Given this list of marker genes Nr4a1, Slc8b1, Fpr2, Pdgfd, Ednrb, Slamf9, Gpr18, Ccl8 (NCBI Gene Id 80561), Dpp4, Itgb2, Ninj1, Akirin1, Cxcl3, Vegfb, Defb6, Cxcr3, Plekhg5, Itgb2l, Mapk1, Epha2, Ccl19-ps6, Kdr, Retnlg, Ccl21e, S100a9, Nrp1, Il17rc, Hbegf, Pdgfra (platelet derived growth factor receptor, alpha polypeptide), C3ar1, Gstp1, Defb3, Bcar1, Gpr183, Trem1, Enpp2, Ccl19-ps5, Spp1, Slc12a2, Csf1r, Prkd1, Kit, Pla2g7, Rab13, Mmp28, Tnfaip6, Lbp, Defb8, Ccl21d, Mtus1, Rac3, Ephb1, Ackr2, Calr, Ccr4, Cxcr4, Msmp, Rac1, Cxcr6, Ccl21f, Cxcl14, Itga9, Sell, Tiam1, Plxnb3, C5ar1, Ccn3, Il12a, Fcgr3, Ccl3, Klrk1 (killer cell lectin-like receptor subfamily K, member 1), Hoxb9, S100a14, Csf1, Fgf1, Dusp1, Cxcr2, Arhgef16, Aif1, Vav1, Nod2, Slit2, Gpr35, Trpm2, Prkcq, Met, Hc, Cxcl16, Tmsb4x, Ccl20, Tnfsf18, Fpr-rs3, Crkl (v-crk avian sarcoma virus CT10 oncogene homolog-like), Ccl21b, Flt1, Mpp1, Hgf, Ccl19-ps4, Plec, Cxcl13, Cklf, Pf4, Ctsg, Swap70, Ptn, Ccl9, Ccl7, Tgfb2, Hmgb1, C5ar2, Srp54a, Rps19, Nup85, Cxcl15, Ripor2, Adam17, Edn3, Scg2, Fgfr1, Ifng, Cxcl12, Prkd2 (protein kinase D2), Shh, Gpsm3, Dapk2, Cxcr1, Grem1, Defb4, Gstp2, Adam10, C1qbp, Il34, Clxn (NCBI Gene Id 74659), Mif, Ccr9, Dnm1l, Mstn, Cmklr1, Rarres2 (NCBI Gene Id 71660), Sbds, Pip5k1a, Coro1b, Ccl17, Bin2, Tnfsf14, Prkca, Rpl13a, Camk1d, Ccr2, Syk, App, Ccl26, Dpep1, Ccl25, Tmem102, Ccl19-ps3, Thbs4, Prex1, Jaml, Cxadr, Itgam, Ppia (NCBI Gene Id 268373), Defb47, Gpr15lg, Defb25, Fpr-rs4, Hsd3b7, Il23a, Edn2, Egr3, Ptprj, Rhog, Agtr1a, Lef1, Cyp7b1, Cnr2, Il17ra, Il17b, Il1b, Mst1, Zfp580, Fgf16, Defb5, Fgf4, Pikfyve, Lpar1, Rac2, Ptk2b, Hspb1, Cxcl2, Defb33, Xcr1, Cx3cr1, Ccr5, Lgals3, Pde4d, Ccr3, Defb7, Mmp9, Ccl4, Abcc1, Nckap1l, Parva, Ccl19, Tirap, Mospd2, Mdk, Trem3, Ccl2, Gab1 (growth factor receptor bound protein 2-associated protein 1), Nbl1, Dock4, Csf3r, Edn1, Coro1a, Ccl12, Wnk1, Serpine1 (serine (or cysteine) peptidase inhibitor, clade E, member 1), Pde4b, Slamf8, Vcam1, Crk, Cxcl10, Spi1, S100a8, Ccl21a (C-C motif chemokine ligand 21 (serine)), Gas6, Ccl6, Ptk2, Defb46, Ccr1l1, Fgf2, Cxcl5, Il4, Ccl27a, Xcl1, Fpr-rs6, Ptpro, S1pr1, Pgf, Bst1, Vegfc, Perp, Tafa4, Vegfd, Lyst, Padi2, Tnfsf11, Cx3cl1, Hrg, Myo9b (NCBI Gene Id 17925), F2rl1, Bsg, Fcer1g, Ccr8, Gm5849, Dysf, Ccl1, Agtr1b (NCBI Gene Id 11608), Ccr6, Cxcl1, Hmgb2, Slc37a4, Nedd9, Ednra, Vegfa, Gbf1 (golgi-specific brefeldin A-resistance factor 1), Ffar2, Nox1 (NADPH oxidase 1), Ccl5, Saa3, Tpbg, Ccrl2, Alox5, Cd74, Cxcr5 (NCBI Gene Id 12145), Snai2, Cxcl17, Trpv4, Ccl28 (C-C motif chemokine ligand 28), Elmo2, Vav3, Ackr3, Trpm4 (NCBI Gene Id 68667), Ccl19-ps1, Prkcd, Sema5a, Arrb2, Lox, Anxa1, Il16, Eng, Ccl11, Slamf1, Lyn, Defb48, Ccl24, Notch1, Creb3, Mmp2, Cyp19a1, F7, Ppbp, Ccr10, BC037156, Ackr4, Cxcl9, Adam8, Gm6040, Oxsr1, Rin3 (NCBI Gene Id 97835), Lgmn, Fpr-rs7, Ccl22, Smoc2, Agr2, Defb14, Mcu, Ano6, Ccr1 (C-C motif chemokine receptor 1), Stk39, Ccr7, Ch25h, Jam3, Cxcl11, P2rx4, Fgf18, Mapk3, Pdgfb, Ppib, Wnt5a, Thbs1, Lgals9, Chga, Pdgfrb, Arhgef5, Stap1, Itga1, here is a description of the gene set: The directed movement of a motile cell guided by a specific chemical concentration gradient. Movement may be towards a higher concentration (positive chemotaxis) or towards a lower concentration (negative chemotaxis). species: Mus musculus Mouse Gene Set: GOBP_CELL_CHEMOTAXIS